The following is a description of a gene set: Reactome Pathway: TGFBR3 PTM regulation This event has been computationally inferred from an event that has been demonstrated in another species.<p>The inference is based on the homology mapping from PANTHER. Briefly, reactions for which all involved PhysicalEntities (in input, output and catalyst) have a mapped orthologue/paralogue (for complexes at least 75% of components must have a mapping) are inferred to the other species. electronically inferred by orthology from the curated human pathway part of: Signaling by TGFBR3 studied in species Mus musculus, and this is the list of marker genes: Psen1, Timp1, Mmp14, Psenen